Given this list of marker genes Tuba3b, Fkbpl, Psma3, Plk1, Psmd12, Tuba1a, Tuba8, Psmd13, Tubb4b, Psmd1, Rps27a, Cdk1, Psma1, Psmd6, Psmb5, Tubb6, Gtse1, Tubal3, Psmc6, Psma2, Tuba4a, Psmc4, Ccnb1, Tuba1c, Psmc1, Psma5, Trp53, Psma6, Tubb2b, Psma4, Psmc3, Psmc5, Tuba1b, Psmb7, Psmc2, Psmb4, Cdkn1a, Psmd7, Ubb, Psmb6, Psma7, Tubb4a, here is a description of the gene set: part of: G2/M Transition electronically inferred by orthology from the curated human pathway This event has been computationally inferred from an event that has been demonstrated in another species.<p>The inference is based on the homology mapping from PANTHER. Briefly, reactions for which all involved PhysicalEntities (in input, output and catalyst) have a mapped orthologue/paralogue (for complexes at least 75% of components must have a mapping) are inferred to the other species. Reactome Pathway: The role of GTSE1 in G2/M progression after G2 checkpoint studied in species Mus musculus